Given this list of marker genes Rae1, Wdr33, Nup54, Ndc1, Fip1l1, Nup93, Seh1l, Aaas, Nup58 (NCBI Gene Id 71844), Nup210, Nup133, Nup155, Nup205, Nup85, Alyref, Cpsf3 (cleavage and polyadenylation specificity factor 3), Cpsf1, Nup42, here is a description of the gene set: Reactome Pathway: Transport of Mature mRNA Derived from an Intronless Transcript electronically inferred by orthology from the curated human pathway studied in species Mus musculus This event has been computationally inferred from an event that has been demonstrated in another species.<p>The inference is based on the homology mapping from PANTHER. Briefly, reactions for which all involved PhysicalEntities (in input, output and catalyst) have a mapped orthologue/paralogue (for complexes at least 75% of components must have a mapping) are inferred to the other species. part of: Transport of Mature mRNAs Derived from Intronless Transcripts